Given this list of marker genes Mkrn2, Flt3, Fyn, Ppp1r2, Cltb, Serpine1, Guca2a, Hr, Dvl3 (NCBI Gene Id 13544), Serpinh1 (serine (or cysteine) peptidase inhibitor, clade H, member 1), Adrb3, Polr2h, Serpina1a, Vps26c, Ndufb3, Cacna1s, Akr1c13 (aldo-keto reductase family 1, member C13), Gtf2h1, Foxd1, Rnaseh2a, Sub1, Vav1, Bach1, Dnajb12, Pabpn1, Cish, Aldh7a1, Sorbs3, Btg3 (NCBI Gene Id 640416), Ptpn18, Lcn3, Rras2, Csf2rb, Hps4, Tubb4b, Cct4, Gap43, Acp5, Polr1e, Rps27 (NCBI Gene Id 69272), Ube2e3, Dhps, Tubgcp4 (NCBI Gene Id 74395), Snrpb, Selenow, Fcgr2b, Acadl, Wnt1, Hps1, Renbp, Pde1b, Tubgcp3 (tubulin, gamma complex component 3), Dynlt1b, Dlx5, Utp4, Ogg1, Mrps18b, Acyp2, Nptx1 (neuronal pentraxin 1), Creld2, here is a description of the gene set: Obesity is strongly correlated with type 2 diabetes mellitus, a common disorder of glucose and lipid metabolism. Although adipocytes are critical in obesity, their role in diabetes has only recently been appreciated. We conducted studies by using DNA microarrays to identify differences in gene expression in adipose tissue from lean, obese, and obese-diabetic mice. The expression level of over 11,000 transcripts was analyzed, and 214 transcripts showed significant differences between lean and obese mice. Surprisingly, the expression of genes normally associated with adipocyte differentiation were down-regulated in obesity. Not all obese individuals will become diabetic; many remain normoglycemic despite profound obesity. Understanding the transition to obesity with concomitant diabetes will provide important clues to the pathogenesis of type 2 diabetes. Therefore, we examined the levels of gene expression in adipose tissue from five groups of obese mice with varying degrees of hyperglycemia, and we identified genes whose expression strongly correlated with diabetes severity. This group included many genes that are known to be involved in signal transduction and energy metabolism as well as genes not previously examined in the context of diabetes. Our data show that a decrease in expression of genes normally involved in adipogenesis is associated with obesity, and we further identify genes important for subsequent development of type 2 diabetes mellitus. from publication Nadler ST, Stoehr JP, Schueler KL, Tanimoto G, Yandell BS, Attie AD (PMID 11027337) Mouse Gene Set: NADLER_HYPERGLYCEMIA_AT_OBESITY Genes correlated with the development of hyperglycemia in obese mice. species: Mus musculus